The following is a description of a gene set: Mouse Gene Set: GOBP_REGULATION_OF_ANATOMICAL_STRUCTURE_MORPHOGENESIS Any process that modulates the frequency, rate or extent of anatomical structure morphogenesis. species: Mus musculus, and this is the list of marker genes: Tbccd1, Pax9, Chodl, Gata5, Fes, Wt1, Dvl3, Mfn1, Numbl, Zmym6, Kalrn, Arhgap4, Hecw2, Fgfr2, Apela, Abi3, Cdkl3, Ninj1, Efna1, Mapt, Uts2r, Vegfa, Itgax, Ajap1, Efnb3, Qki, Nedd4l, Map3k13, Foxp1, Dmrt2, Fmnl3 (NCBI Gene Id 72414), Fam171a1, Aurka, Sash1, Tert, Tgfb1, Rreb1, Csf1, Msx1, Tgfbr2, Rac2, Adcy10, Fbln5, Snap91, Parvb, Tanc2, Agtr2, Pak3, Hnrnpk, Pdcl3, Bnip3, Macf1, Myl12a, Sp1, Strip2, Rims1, Eef2k, Gpr4, Tspan12, Rock2, Anapc2, Rims2, Ptger4, Itsn2, Tgm2, Tiam2, Six4, Rdx, Sfrp1, C3, Cfap410, Notch4, Plxnd1, Myo9a, Bdnf, Parva, Pf4, Myh14, Lpar1, Lrrc4c, Caprin1, Taok2, Cit, Gadd45a, Pkn1, Tnfsf13, Hes1 (NCBI Gene Id 15205), Sema3f (NCBI Gene Id 20350), Bmpr1a, Cdc42ep2, Braf, Pak2, Syngap1, Dip2b, Adgrb2, Wasf3, Runx1, Gdi1, Ada, Dixdc1, Tpm1, Ccl24, Pxn, Ephb2, Tek, Rhob, Wnt7a, Bmp2, Abi3bp (NCBI Gene Id 360036), Cyfip1, Add1, Arhgap35, Spta1, Hoxc11, Lgals3, Gata2, Hspb1, Twf2, Gorasp1, F2, Fyn, Tnmd, Cemip2, Ep300, Efna3, Irgm1, Ddah1, Dkk1, Oma1, Smo, Tbx2, Ccl12, Nkx6-3, Cdk5, Enam, Ntng2, Dbnl, Osr1, Sema5a, Hdac6, Ecscr, Map1b, Mir27a, Ccl3, Wars2, Adam12, Reln, Ccbe1, Dll1, Ptk2, Sema3a, Mef2c, Smurf1 (SMAD specific E3 ubiquitin protein ligase 1), Camp, Flt4, Btbd7, Pdcd6, Dlg1, Gata4, Dnm3, Xlr3b, Rufy3, Ppfia2, Baiap2, Poglut1, Nlgn3, Arhgef18, Fgf1, Cpne6, Grin1, Lpar3, Foxc1, Pdzd8, Mcu, Mfsd2a, Rhog, Lif, Plg, Jup, Rhobtb1, Ptgis, Inf2, Thbs1, Plekho1, Pax3, Epha7, Wtip, Hck, Tnfrsf11b, L1cam, Spart, Cdh4, Tnn (tenascin N), Tenm4, Vegfc, Tnfrsf1a, Mtch2, Shtn1, Ppp1r15a, Hoxd11, S100b, Atp2b4, Ist1, Carlr (NCBI Gene Id 66774), Prkn, Tnf, Nedd4, Shank3, Fgf2, Cela1, Skil, Angptl3, Rap2a, Cul7, Aqp1, Palm3, F11r, Coro1c, Septin7, Tacstd2, Lgr4, Fis1, Rtn4, Syt4, Tmem135, Mul1, Phb2, Gja1, Rapgef2, Gata6, Arhgap15, Picalm, Trpv2, Sp100, Hoxa11, Tnfaip3, Phip, Emilin2, Adck1, Ngef (neuronal guanine nucleotide exchange factor), Zdhhc6, Tsc2, Hmgb1, Jcad, Cited2, Myo5b, Shroom3, Htatip2 (HIV-1 Tat interactive protein 2), Opa1, Zmym4, Prkd1, Xbp1, Il1a (NCBI Gene Id 16175), Chn1, Rtn4r, Sox8, Ppargc1a, Ramp2, Sema3g, Arhgdia, Ptprm (protein tyrosine phosphatase receptor type M), Coch, Cdx1, Fgf7, Draxin, Ryk, Six1, Sprr2a1, Wnt3, Epb41l3 (NCBI Gene Id 56528), Gdf2, Anxa3, Spry2, Epha2, Clic3, Ntn1, Myo19, Erap1, Epb42, Itpka, Pakap, Agt, Prkd2, Psg22, Tgif1, Golga4, Brsk2, Adamts1, Tjp1 (tight junction protein 1, NCBI Gene Id 381892), Dlc1, Pdpn, Mief1, Foxa2, Adgrb1, Fn1, Cntn2, Ednra, Neurog3, F3, Bmp7, Sec24b, Fut1 (fucosyltransferase 1), Fbxw8, Cpne9, Nog, Gm14137, Csf1r, Pparg, Ccr3, Itgb2l, Srcin1, Tfrc, Sp6, Cxcl12, Foxc2, Lzts1, Ube3a, Edn1, Angpt2, Pias2, Plxnc1, Cd34, Epb41l2, Plxnb2, Pafah1b1, Tafa5, Wnt4, Sema4f (NCBI Gene Id 20355), Stard13, Sulf1, Ifrd1, Slc23a2, Met, Nrdc, Prkcb, Maged1, Ulk2, Cxcr3, Cdc42ep4, Eps8, Mag, Pgk1, Ermn, Phldb1, Gsk3b, Phldb2, Rhou, Jak1, Cybb, Dkk4, Ptprd, Ntng1, Ptn (pleiotrophin), Emp2, Vps35, Arhgap32, Hoxb7, Zmym3, Parp6, Spag6l, Adam10, Hmox1, Arpin, Pou3f2, Itga5, Sema6d, Cd40, Grem1, Marchf5, Jag1, Rala, Efna5, Fmnl2, Nin, Pde3b, Synj2bp, Notch1, Ets1, Mir24-1, Cd36, Runx2, Gna13, Strip1, Itga7, H2-DMa, Nlgn1, Lrp1, Foxj2, Palmd (NCBI Gene Id 66688), Wars1, Tnik, Ighm, Shh, Prkca, Pink1 (NCBI Gene Id 68943), Plxnb1, Nos3, Hhip, Vil1, Map2k1, Abcc8, Cdk5r1, Ccm2, Ppp3ca, Syne3 (spectrin repeat containing, nuclear envelope family member 3), Pik3cd, Pou4f2, Otx2 (orthodenticle homeobox 2), Cdx2 (caudal type homeobox 2), Spire1, Snai2, Kif3a, Mov10, Tbx1, Pten, Itgb3, Clasp2, Jhy, Bmper, Cst3, Ypel4, Ccr5, Ccl5, Mydgf, Il17f, Irgm2, Mmp9, Bambi, Fzd4, Chrnb2, Ccl7, Foxo4, Rhoq, Agtr1b, Adamts12, S100a13, Arhgap44, Flt1, Ptprz1, Rasal1, Acvrl1, Hgs, Skor2, Apoe, Stk11 (serine/threonine kinase 11), Plk2, Dcn, Dag1, Zmpste24, Dvl2, Yjefn3, Ngf, Dnmbp, Tspan18, Adgrb3, Rela (v-rel reticuloendotheliosis viral oncogene homolog A (avian)), Apoh, Cdkl5, Tlr3, Omg, Wls (wntless WNT ligand secretion mediator), Pak1, Enpp2, Vat1, Hmga2, Ecm1, Wnt5a, Fitm2, Il6, Sh3kbp1 (SH3-domain kinase binding protein 1), Nrp1, Wdr1, Cacna1a, Pld6, 4930550C14Rik (RIKEN cDNA 4930550C14 gene), Crk, Xk, Eif2b2, Fgfr4, Lrp8, Golga2, Chi3l1, Abr, Cfl1, Sall1, Dhx36, Ngp, Dab2ip (disabled 2 interacting protein), Pgf, Limd1, Il10, Ankrd27 (ankyrin repeat domain 27), Ngfr, Sphk1, Hpn, Pdgfa, Disc1, Ust, Epha1, Myo10, Il18 (NCBI Gene Id 16173), Hecw1, Vash1, Pdpk1 (3-phosphoinositide dependent protein kinase 1), Nherf1, Adgra2, Brca1, Angpt4, Nras, Gab1, Fgf8, Stox1, Lcn2, Syt2, Cd59a, Epb41, Sh2b3, Cldn5 (claudin 5), Spred1, Mir23b, Pax8, Mbp, Mark2, Sfrp2, Tgif2, Vash2, Rnf157, Cysltr2, Amot, Cacng7, Pax2, Prl2c2, Nf1, Shc1, Cx3cr1, Dtnbp1, Rras, Pdcd10, Slitrk1, Bves, Nfatc3, Adnp, Sh3glb1, Mt3, Cdc42se2, Fgf18, Prl7d1, Cdc42ep5, Atf2, Lst1, Fgr, Esr1, Brwd1, Rnf207, Rack1, Ahi1, Ift88, Hk2, Tcf4, Rhobtb2, Brsk1, Gas7, Rnh1, Trim46, Hgf, Dab1, Anxa1, Actr2, Slit2, Stau2, Ar, Sema7a, Btg1, Scx, Uts2, Ago2, Mapk7 (NCBI Gene Id 23939), C3ar1, Ppp1r9a, Hrg, Gas2, Ctsh, Pgam5, Rnf6, Mir875, Nsmf, Lrrk2 (leucine-rich repeat kinase 2), Creb3l1, Cma1, Six2, Fgf13, Sapcd2, Tmbim1, Cfdp1, Pak4, Mir23a, Megf8, Cdh5, Ghsr, Mfn2, Fgf10, Wnt2, Egf, Rock1, Ddhd1, Stat1, Rab21, Dsg2, Col4a2, Vangl2, Hc, Aggf1, Limk1, Sgk1, Wnk1, Osr2, Ddhd2, Slit1, Jmjd8, Pik3r6, Hipk2, Ccr2, P2ry1, Ostn, Mir539, Zdhhc15, Nodal, Cdc42se1, Mief2, Eng, Zc3h12a, Cxcr4 (C-X-C motif chemokine receptor 4), Gm28729, Sema6a, Cyrib, Ctnnb1, Thy1, Akt3, Hhex, Atg16l1, Fstl4, Stat3, Wnt3a, Pkm, Or10j5, Ndel1, Smoc2, Tbc1d24, Plcg1, Kif1a, Aldoa, Minar1, Ralbp1, Isl1, Fgd4, Sfrp5, Islr2, Cd160, Il1b, Pkhd1, Msn, Nefm, Ptprf, Thbs2, Apc, Rgma, Cldn13, Rac3, Lbx2, Mpl, Tnfrsf13c, Ism1, Unc13a, Tiam1, Stab1, Zfp354c, Wnt10a, Abl1, Myh10, Ephb4, Bhlhb9, Map6, Nr2e1, Ghrl, Kit, Gata3 (NCBI Gene Id 14462), Ntrk1, Wdpcp, Mkln1, Palm, Syt3, Ppp1r16b, Rxra, Ptprs, Map2k2, Kndc1, Slc12a2, Gna12, Mir27b, Syt17, Psen1, Wnt2b, Dapk3, Cpne5, Hnf4a, Actr3, Metrn, Sema6c, Pik3cg, Sparc, Fermt2, Chrna3, Rbpj (NCBI Gene Id 791349), Sdc2, Fmnl1, Obsl1, Cldn3, Ccl2, Pqbp1, Ulk1, Marcks, Emc10, Dscam, Stk25, Aplnr, Itgb1, Cask, Rac1, Camsap1, Kel, Hspb6, Arap1, Lzts3, Akap5, Arhgap33, Rspo2, Abi2, Trak2, Yme1l1, Kdr, Cldn4, Trak1, Slc26a5, Nfatc4, Pum2, Rc3h1, Camk2b, Hoxa5, Frs2, Mff, Prag1, Apcdd1, Shox2, Zranb1, Lhx1 (LIM homeobox protein 1), Pml, Alox5, Stat2, Coro1a, Plaa (NCBI Gene Id 52374), Cnmd, Ntrk3 (NCBI Gene Id 414121), Diaph1, Fbxo31, Ccn6, Cxcr2, Cux2, Bcl11a, Ceacam1, Serpinf1, Trpc6, Mmrn2, Hoxd13, Pdgfra, Id1, Amigo1, Lep, Trpc5, Gla, Arc, Ago4, Cysltr1, Fuz, Fgf3, Col4a3, Emilin1, Sh3d19, Prkdc, Pdlim5, Ache, Foxj1, Sars1, Plxna3, Coro1b, Ccl11, Myh9, Klf4, Optc, Etv5, S2bpcox16, Adm2, Cd44, Slc30a1 (NCBI Gene Id 98435), Dlg4, Gdnf, H2-M3, Kank1 (NCBI Gene Id 77823), Nefl, Igtp, Cux1, Glul, Sema3e, Syt1, Dmrt3, Il1rapl1, Crhr2, Rhoj, Fxn, Stim1, Bcl9l, Huwe1, Krit1, Itgb8, Dvl1, Robo1, Pik3cb (NCBI Gene Id 74769), Clasp1, Cdh1, Efnb2, Thbs4, Sarm1, Alox12, Fkbpl, D130043K22Rik, Dhodh, Slc39a12, Rapgef3, Ntrk2, Cdc42ep3, Klf2, Caprin2, Grip1, Tlx2, Ret, Itgb2, Src, Afdn, Prok1, Dcx, Tnfrsf12a, Epha4, Anxa7, Cav3, Ywhah, Dicer1, Dbn1, Cdh2, Hif1a, Fgd1, Cyp1b1, Eif4g2, Agtr1a, Map2, Nfe2l2, Ntn4, Spag9, Ptpn6 (protein tyrosine phosphatase, non-receptor type 6), Epn1, Zfyve27, Lfng, Larp4, Bmpr2, E2f2, Kif13b, Hexb, Cpe, Crabp2, Sema4a, Zeb2, Ss18l1, Brwd3, Nf2, Robo2, Tbxa2r, Mir329, Ilk, Ptk2b, Plxnb3, Reck, Icam1, Serpine1, Hyal1, Rnd2, Bcr, Smad1, Rgcc, Mesp1, Adrb2, Tie1, Sec1, Sema4d, Capzb, Epn2, Adm, Spry1, Cdc42ep1, Mtdh, Ttc3, Adamts9, Gtf2i, Egln1, Reg1 (regenerating islet-derived 1), C5ar1, Dpysl5, Cxcl10, Fasl, Sirt6, Numb, Lrp4, Vim, Tnr, Ago1, Fgfr1, Tgfb2, Vegfb, Myl12b, S100a1, Mdk, Tnfsf13b, Mir24-2, Sirt1, Srf, Lrg1, Rpl4, Fblim1, Arhgap18, Grn, Prpf40a, Bmp4, Ephb3, Crb2, Mecp2, Sprr1b, Ezr, Igf2, Naxe, Wnt5b, Parvg, Sox9, Dnm1l, Sipa1l1, Dmtn